The following is a description of a gene set: Any process that increases the frequency, rate or extent of the regulated release of norepinephrine. Mouse Gene Set: GOBP_POSITIVE_REGULATION_OF_NOREPINEPHRINE_SECRETION species: Mus musculus, and this is the list of marker genes: Oxtr, Plcd1, Kcnb1, Adora2b, Oxt, Stx1a